The following is a description of a gene set: studied in species Homo sapiens Human Gene Set: GOBP_POSITIVE_REGULATION_OF_DENDRITIC_SPINE_MORPHOGENESIS Any process that increases the rate, frequency, or extent of dendritic spine morphogenesis, the process in which the anatomical structures of a dendritic spine are generated and organized. A dendritic spine is a protrusion from a dendrite and a specialized subcellular compartment involved in synaptic transmission., and this is the list of marker genes: IL1RAPL1, DBN1, ARMCX5-GPRASP2, SLC30A1 (NCBI Gene Id 7779), CAMK2B, STAU2, ITPKA, RELN, PAFAH1B1, PTPRD, CUX2, BAIAP2, EPHB2, DHX36, CAPRIN2, LRP8, GPRASP3, EEF2K, CAPRIN1 (NCBI Gene Id 4076)